Given this list of marker genes TRIM15, NODAL, KLF4, PAX2, BMPR1A, BMP4, SIX2, HOXA11, EYA1, SFRP2, FOXC2, MESP1, TBX6, DKK1, FGFR1, SMAD1, EYA2, WNT3A, here is a description of the gene set: The cell differentiation process that results in commitment of a cell to become part of the mesoderm. Human Gene Set: GOBP_MESODERMAL_CELL_FATE_COMMITMENT species: Homo sapiens